The following is a description of a gene set: Any process that activates or increases the frequency, rate, or extent of interleukin-6 production. Human Gene Set: GOBP_POSITIVE_REGULATION_OF_INTERLEUKIN_6_PRODUCTION species: Homo sapiens, and this is the list of marker genes: TLR6, IL36A, LILRB2, F2R, CLEC7A, CD36, NOD1, IL17F, IL17RC, SCIMP, PYCARD, TNF, IL33, MIR92A1, SETD4, TRAF6, TLR4, SYK, INAVA, CARD9, CD74, RIGI (RNA sensor RIG-I), MBP, SIGLEC16, IL17A, CYBA, TMEM106A, ARHGEF2, IL16 (NCBI Gene Id 3603), MAVS, BCL10, TLR1, LGALS9, MIR144, AKIRIN2, STAT3 (NCBI Gene Id 6774), MAPK13, FCER1G, SELENOK, WNT5A, IL6R, TNFSF4, TLR3, BSG, TWIST1, RAB7B, LILRA2, IL1B, MIR657, EREG, IFNG, ARID5A, POU2F2, PLCG2, IL17D, BTK, IL1RL2, DHX9, AGER, HYAL2, LAPTM5, IL17RA, UCN (NCBI Gene Id 7349), MYD88, TICAM1, AIF1, F2RL1, NOS2, TLR2, TLR9, P2RX7, HMGB1, POU2AF1, IL6, RIPK2, C1QTNF4, TLR8, SPON2, IFIH1, TGFB1, UNC93B1, HSPD1, SPHK2, RELA, NLRP10, LBP, LPL, ZBTB20, TSLP, IL1A, NOD2, TRPV4, LILRA5, ISL1, TYROBP, IL1RAP, ADORA2B, APP, TIRAP, XBP1, LEP, DEFB124, TLR7